Given this list of marker genes APPL1, BSCL2, SARS2, HBS1L, ERH, IQGAP2, EMILIN1, ITM2C, LAPTM4B, SLC11A1, POLR2C, TMEM140, GALNS, RFC5, ARHGAP21, ANLN, THY1, XKR5, PPT2, SND1, ECSCR, CDC25C, CDC16, TBC1D31, TFAP2E, ZSCAN25, RTN3, CORO2B, SHQ1, RPUSD3, CCPG1, PIK3R5, RAB32, FCGR2A, LGALS3, YIPF2, ARHGAP28, RPP14, SREK1, CPXM1, SERF1A, PEX11A, HASPIN, CKAP2, PSMA6, PYCR2, TOR1B, SLC7A3, COMMD5, SELENOH, NDUFA8, NNT, TMEM38B, TMEM70 (NCBI Gene Id 54968), BRCC3, AKAP1, PIGB, CLTB, PHGDH, CDKN2C, COX4I2, ALDH9A1, KIFC1, IMPA2, NEPRO, GOLGA3, FBXO17, RAB1A, DCTPP1, ZWINT, CCDC186, SUDS3, ESF1, MRPS11, METRN, PSMD1, TBC1D8, UQCRC1, DSTN, LMO4, MRPL36, CPPED1, GRK4, MAP3K10, IZUMO1, DHRSX, DNAJB11, LEO1, BATF3, SYAP1, GDAP2, H2AZ1, AURKA, TNFSF10, CHTF18, IER3, HARBI1, RIPPLY3, NDUFB11 (NADH:ubiquinone oxidoreductase subunit B11), ACER3, RAB3D, TMEM263, RNF26, ENTPD7, GMDS, XRCC3, EIF5B, ENPP4 (ectonucleotide pyrophosphatase/phosphodiesterase 4), NDC80 (NCBI Gene Id 10403), MTM1, OIP5, PSENEN, E2F2, TBL2, CERS2, C8orf34, CDC42SE2, MTIF2, PBX1, NDFIP1, NSMCE2, CUBN, LCORL, PFKM, TRAPPC6A, CIAO3, RAD18, MRPS10, COASY, PRR11, TPST1 (tyrosylprotein sulfotransferase 1), PHAF1, BAAT, DIS3L, ATP5PF, FNIP2, MRPS22, MALSU1, TRMT10A, TEX2, ANXA1, MGLL, CANX, IDE, RNASEK, PEX2, MSANTD4 (NCBI Gene Id 84437), ADK, NDUFAF7, CCDC146, ELP5, C2, TMEM101, EXOC6B, SCCPDH, EFCAB3 (EF-hand calcium binding domain 3), PSMD12, RAB26, COMMD9, NDUFA10, ATP5MG, SLC33A1, DHFR, NDUFC2, AP1S1, GNB4 (G protein subunit beta 4), APOO, RECQL4, PSIP1, SCARF2, ETFDH, PROCR, SYS1 (NCBI Gene Id 90196), PRSS16, ARF4, MTFP1, PMM1, CNIH4, CHRNB4, DDIAS, ARL5A, CDC45, GLRX2, IFRD2, SLC38A10, RAB4A, TPX2, PON1 (paraoxonase 1, NCBI Gene Id 5444), B3GALT5, CD300A, SLC7A6, ALG14, RAD51AP1, SAP18, PXMP2, CACNA1E, CENPU, CXCL10, COPS2, TBCB, here is a description of the gene set: Human Gene Set: GSE2770_IL12_VS_IL4_TREATED_ACT_CD4_TCELL_48H_UP Th1 and Th2 cells arise from a common precursor cell in response to triggering through the TCR and cytokine receptors for IL-12 or IL-4. This leads to activation of complex signaling pathways, which are not known in detail. Disturbances in the balance between type 1 and type 2 responses can lead to certain immune-mediated diseases. Thus, it is important to understand how Th1 and Th2 cells are generated. To clarify the mechanisms as to how IL-12 and IL-4 induce Th1 and Th2 differentiation and how TGF-beta can inhibit this process, we have used oligonucleotide arrays to examine the early polarization of Th1 and Th2 cells in the presence and absence of TGF-beta after 0, 2, 6 and 48 hours of polarization. from publication Lund R, Aittokallio T, Nevalainen O, Lahesmaa R (PMID 14607935) studied in species Homo sapiens Genes up-regulated in CD4 T cells activated by anti-CD3 and anti-CD28: IL-12 (48h) versus IL4 (48h).